The following is a description of a gene set: Human Gene Set: MORF_IL9 species: Homo sapiens Neighborhood of IL9 Neighborhood of IL9 interleukin 9 in the MORF expression compendium, and this is the list of marker genes: ZNF239, DOC2A, GLRB, KCNA3, VPS41, EPHA7, ATRNL1, PRM2, CBLIF, KCNJ13, SCN2A, MYBPH, TPH1 (NCBI Gene Id 7166), ADAM7 (ADAM metallopeptidase domain 7), AVP, CXCR6, RPGRIP1L, BRDT, SLC2A4, HDAC9, RASGRF1, P2RY6, BMPER, HOXD9, WIPF1, KRT37, NLE1, LCAT, LRRTM2, TCF15, ATG4B, SEC14L2, RFX1, DMP1, MLLT3, PDCL, ODF2, NEU3, CRP, HIPK2, FSTL4 (follistatin like 4), PRORP, GPR176, KCNH1, IFNA4, FOXN2, MPHOSPH8, GCNT2, AVPR1A, ANGPTL7, DCC, RPGRIP1, SYT11, CHRNA3, ADGRB3, ZNF264, SPAG8, COX10, IL9 (NCBI Gene Id 3578), NACAD, SERPINC1, SLCO2A1, COG7, ZFY, TCF21, AKR1D1, TNNI2, GK2, MATN4, BAAT, EIF2B1, DCAF4, UGT2B4, GPR4, ART3, SOX3, CYP1A2, C1orf21, RBM17, TRIM9 (NCBI Gene Id 23206), NLGN4Y, LCT, SAA4, CASQ2, MINAR1, HAVCR1, IL18RAP, SPAM1, FRK, ASTN1, FAM13C, SSX5, TEKT2